Given this list of marker genes RCAN2, ZNF57, LDLRAD4, SLIT1, SLC39A14, SELENOS, MIR155HG, DMAC1, LYPLA1, IRF4, SPATS2L, MSMO1, TNFRSF9, EPAS1, NDUFAB1, BLTP3B, URM1, SPACA9, TFRC, RFTN1, MTMR2, SCP2, SS18, COMMD3, SARNP, KYAT3, AGPAT5, NME7, SLC9B2, TM9SF4, GNPAT, CAMK2D, EFHD2 (NCBI Gene Id 79453), INPP1, QSOX2, RAB37, GPRIN3, EMILIN2, NHS, KCNN4, NDUFB5, LRRCC1, SLC15A4, GSDME, RDH10, CLYBL, PDE4D, CD72, COPRS, GM2A, F5, BPNT2, GTF2H5 (NCBI Gene Id 404672), ZNF282, EIF2B2, RAB13, CPPED1, COX5A, RAC2, IRAK2, NDUFA8, FGGY, GNG5, LAG3, ZFYVE1, DELE1, WIPI1, SIRPG, HIVEP1, MRPL47, MEAK7, HS2ST1 (heparan sulfate 2-O-sulfotransferase 1), GNGT2, VSIG10L, ACTMAP, CCT8, PTGR3, MCTP2, CD109, LPP, FDFT1, HSD17B10, PFDN4, NDUFA7, TBCE, PRPF6, TNFRSF1B, YARS1 (NCBI Gene Id 8565), SUOX (sulfite oxidase), SLC7A5, UEVLD (NCBI Gene Id 55293), SLC12A6, METRNL, FAM210A, DPP4, TNFRSF11A, SNRPF, PPP1R16B, BTBD3, SLC35G2, BCAT1, GCA, ITGAE, CIAO2B, PAQR6, EVI5 (ecotropic viral integration site 5), GK, EGR2, LRRC28, B3GNT5 (NCBI Gene Id 84002), TTN, RNF7, LYRM4, ZMIZ1, SLC25A13, PTTG1, NR4A3, ZNRF1, CACNA2D4, CHP1, FAH, CMTM7, STAMBP, GTDC1, EIF3J, PRDM1, SEC11A, SYTL3, PNKP, TXNL4A, NOD2, COPS8, ANTXR2, WSB2 (WD repeat and SOCS box containing 2), LANCL2, CREB3L2, DUSP2, GNA15 (G protein subunit alpha 15), STAM, TJP2, BMAL2, PIGX, FOSL2, BMP2K, STYXL1, MRPL42, DBI, IER3, STAG3, BOLA3, BCL2L1, SLC31A1, SPTSSA, GNA12, SEC61G, DHCR24, THOC7, UBE2G1, ERP44, CCDC141, TIMM23, NEDD9, VPS8, WDR12, TPM4, EIF2S2, ITGAX (integrin subunit alpha X), RASSF2, TMEM185A, FAM221A, IRAK1BP1, SQLE, SEC61A2, PPP2R5A, CHMP5, BYSL (bystin like), TXNDC17, TRAK1, SFT2D1, RGL4, ADAT2, FDX1, ST8SIA4, DHRSX, GRAMD1B, B3GNTL1, ATP5MJ, TNIP3, HDLBP, RDX, MBD2, SLC25A17, ITGAV, PARK7, PGAM1, SPRY1, SLCO4A1, GEM, SOCS6, GRAMD4, here is a description of the gene set: species: Homo sapiens There is much evidence that T cells may be activated via mechanisms which act independently of direct TCR ligation. Despite this, the question of whether such forms of ‘bystander’ T cell activation occur during immune responses is hotly debated. To address some outstanding questions, we set up an in vitro system within which to analyse bystander T cell activation in human T cells, in the absence of the possibility for TCR cross-reactivity. In addition, we have investigated the genetic, phenotypic, and functional characteristics of bystander activated T cells. Here, we show that bystander T cell activation is, indeed, observed during a specific immune response, and that it occurs preferentially amongst CD4+ memory T cells. Furthermore, bystander activated T cells display a distinct gene expression profile. The mechanism for bystander T cell activation involves soluble factors, and the outcome is an elevated level of apoptosis. This may provide an explanation for the attrition of T cell memory pools of heterologous specificity during immune responses to pathogens such as viruses. from publication Bangs SC, Baban D, Cattan HJ, Li CK, McMichael AJ, Xu XN (PMID 19201849) Genes down-regulated in comparison of resting CD4 T cells versus directly activated CD4 T cells. Human Gene Set: GSE13738_RESTING_VS_TCR_ACTIVATED_CD4_TCELL_DN